Given this list of marker genes ADCY5, GNAI1 (NCBI Gene Id 2770), GABRA3, GABRB3, KCNJ5, GNB2, NPTN, KCNJ6, GNG8, ADCY4 (NCBI Gene Id 196883), GNB4, KCNJ2, ADCY6, GABRB1, KCNJ3, GABRA4, GNG5, ADCY9, ADCY3, GABBR2, GABRA1, ADCY2, GABRQ, GABBR1, GNAL, GABRB2, KCNJ16, GNB5, GABRA6 (gamma-aminobutyric acid type A receptor subunit alpha6), GNAI3, GABRA2, GNG3 (NCBI Gene Id 2785), GABRR2, KCNJ12 (NCBI Gene Id 92081), GNB3, GNGT1, KCNJ4, GNG13, ADCY1, GNAI2, KCNJ15, GNG7, GABRR3, KCNJ9, GABRG2, GNG10, GNGT2, ADCY8, ARHGEF9, GABRR1, GNG4, GABRG3, KCNJ10, GNAT3, ADCY7, GNG11, GABRA5, GNG12 (G protein subunit gamma 12), GNB1, GNG2, here is a description of the gene set: Gamma aminobutyric acid (GABA) receptors are the major inhibitory receptors in human synapses. They are of two types. GABA A receptors are fast-acting ligand gated chloride ion channels that mediate membrane depolarization and thus inhibit neurotransmitter release (G Michels et al Crit Rev Biochem Mol Biol 42, 2007, 3-14). GABA B receptors are slow acting metabotropic Gprotein coupled receptors that act via the inhibitory action of their Galpha/Go subunits on adenylate cyclase to attenuate the actions of PKA. In addition, their Gbeta/gamma subunits interact directly with N and P/Q Ca2+ channels to decrease the release of Ca2+. GABA B receptors also interact with Kir3 K+ channels and increase the influx of K+, leading to cell membrane hyperpolarization and inhibition of channels such as NMDA receptors (A Pinard et al Adv Pharmacol, 58, 2010, 231-55). part of: Neurotransmitter receptors and postsynaptic signal transmission studied in species Homo sapiens Reactome Pathway: GABA receptor activation